The following is a description of a gene set: Mouse Gene Set: FOXD3_TARGET_GENES species: Mus musculus from publication Yevshin I, Sharipov R, Kolmykov S, Kondrakhin Y, Kolpakov F (PMID 30445619) Genes containing one or more binding sites for (Foxd3) in their promoter regions (TSS -1000,+100 bp) as identified by GTRD version 20.06 ChIP-seq harmonization., and this is the list of marker genes: Myo6, Mdm4, Tbc1d15, Cntnap5b, Armc9, Ighv8-2, Serpina3h, Snx5, 1700008O03Rik (RIKEN cDNA 1700008O03 gene), Gm11335, Mobp, Or2t43 (olfactory receptor family 2 subfamily T member 43), H3f3b, H2bc22, Snord3a, Cntnap2, Noct, Oxr1, Gm10222, Chd2, Grcc10, Wrap53, H2ac8, Mroh6, H4c9, Zfp74, Tmsb15l, Aloxe3, 2310016D23Rik, Platr6, Gm23143, Adcyap1, Glra1, Gm11528 (predicted gene 11528), Gm3329, Rbpj, Rpgrip1, H3c6, Gpr19, Slc39a3, Cerkl, Il33, Nnmt, Igf1, Csdc2, Snora24, H3c1, Trim36, H3c13, Med16, Fundc1 (FUN14 domain containing 1), Slco2a1, Snord22, Arsi, Nbr1, Ccdc162, Gm11398, Vangl1, Mir290a, Pax6, Avpi1, Lmo4, Cacnb1, Platr8, Tm6sf1, Bdnf, Irak3, Pbx4, Mras, Gm14443, Aasdh, Snx13, Asxl1, Rpl10a, Mir367 (microRNA 367), Cep112, Krt86, Slc9a2, H2bc18, Arl8b, Clk4, H2bc6, Cept1, Fli1, Gm13580, Dennd2c (DENN domain containing 2C), Ctxn2, Cep120, H1f1, Lhx3, Zfp933, Tmem63b, Capsl, Snord13, Snx1, Mapk8ip2, 1700109H08Rik, Apol6 (apolipoprotein L 6), Rnu7, C230035I16Rik, Car10, H2ax, Slc2a3, Chrna9 (NCBI Gene Id 69992), Bola2, Mrfap1, 2610005L07Rik, Thrap3, Gm16096, Slc25a40, Ube2e1, Cyth3, Gjc1, Gm7546, H1f2, H2bc15, Slc5a11, Tceal8, Ncoa3, Hlf, Stmn1, 5830468F06Rik, Foxp1, Mfsd4b5, Slc4a1ap, Spic, Bbs2 (Bardet-Biedl syndrome 2), B3galt4, Platr11, Hs3st2, Tob1, Tmem220, Sbno1, Gm16249, Klhl5, Tdh, Snord49b, Defb1, Twf1, Rbp7, Fgfr2, Rabgap1l, Atxn7l1, Sbds, 2410006H16Rik, Snord43, Neurod4, Liph, Omg, Pgk1, Htr1a (5-hydroxytryptamine (serotonin) receptor 1A), 4930556M19Rik, 9330185C12Rik, Mup6, Ucn, Gm11862, H4c14, Gm23887, Alyref2 (NCBI Gene Id 56009), Crlf1, Stk38, 1700019D03Rik, Polr2a, Scamp1, Tmem131l, Peli2, Pag1, Gm25323, Upp1, Spp1, Acsl6, Eif4a2, Ntn1, H4c4, Ccdc92b, Lrrtm3, Dner, Mrpl58, Phc1, Gm12974, H3c3, Jarid2, Mir122, 2700078F05Rik, Frmd4b, 2410021H03Rik, Hecw2, Ipo11, Or8u8, C430039J16Rik, Skap2, Kctd4, Usp49, Eapp, H2ac15, Gm25878, Gpd2, Srsf2, Pramel7, Tmsb15b1, Gm27217, Gm26907, H1f3, A230072E10Rik, Ebi3, Cbx2, Ap2a2, Atp6v0a1, 1700109G14Rik, Gm14292, Snhg3, Lrrc2, Fancd2os, Pml, Gm11517, Arl6ip1 (NCBI Gene Id 97394), Ldlrad3, H4c6, 4930503O07Rik, A530020G20Rik, Glra2, Zc3h10, Itga6, Mcf2, Rad23a, Cidea, 1700021P04Rik, Zfp976, Car3, Eef1a1, Rps26, Snora73b, Eif4e1b, Cdhr18, Mroh3, Xiap, Xpa, Rcc1, Lpar1 (lysophosphatidic acid receptor 1), Uba2, Rny3, Cxcl11, Brd2, Madd, Gm15660, H2ac4, Alg13, Msh4, Mir302c, Ang2, Gm22513, Prps1, Klf4, Tlr3, Etv5, Trp53bp1, Tti2 (TELO2 interacting protein 2), Lamc3, Mir302d, Fbxo15, Atp6v0a4, Gm35048, H2bc3, Sfrp4, Tgm4, Snhg8, Pdzk1, Zfp212, Ogt, Plcd4, Gm11850, Rnf125, Pde7b, Gm11747, Fis1 (NCBI Gene Id 66437), Mgme1, Gm7804, Plekha1, H2bc12, Gm17501, Tph2, Dhx32, Trim69, Hnrnpu, Nop58, Egr1, Oas1a, Lpar6 (lysophosphatidic acid receptor 6), Cpsf4l, Traf3ip2, Gm25939, Gm26444, Stx1a, Spink1, Fam124b, H3c10, Rerg, Rnu11, Arf4, Dnah14, C330002G04Rik, 4930442L01Rik, Gm25053, Mterf2, Tmem11, Trbv31 (NCBI Gene Id 269846), Porcn, Gm12017, Arl5b, Tdrp, Tg, H2ac11, Nudt3, H2-T24, Mroh1, Agtrap, H2bc8, Gm22744, Rev1, Slc25a1, Zfand6, Tmcc1 (transmembrane and coiled coil domains 1), Sms, H4c3, Schip1, Scpep1os, Prkci, Armcx1, Mir292, Scn2a, Ackr4, Ctbp2, Scg2, Hmgxb4 (NCBI Gene Id 70823), Gm23246, Garin1a, Emc4, Lss, N4bp2, Gm28857, Gls, Mir291b, Gm16510, Cacng3, Pura, Cadps, Snapc5, Fgfr1, Yars2, Slc38a2, Trip12, Scmh1, Setd5, H4c1, 4930453N24Rik, Cdkl3, Npdc1, Btf3-ps11, Poldip3 (NCBI Gene Id 97955), Mbnl1, Mtcl1, 1600014C10Rik, Cpeb3, Barhl1, Rnu12, Gapdh, Supt7l, Il1rapl1, Golga1, Gramd1a, Pef1, Ubc, Gm20609 (NCBI Gene Id 102637684), Oas1g, H4c12, Skp1 (NCBI Gene Id 76591), H2af-ps2, Rpl3, 4933417E11Rik, Snx10 (NCBI Gene Id 71982), Ssr2, Atf7ip, Fam169a, Rxfp3, Gt(ROSA)26Sor, Mir6236, Dapk3, Capzb, Gm9791, Mir302a, Gm12925, Trem2, Zfp975, Nrf1, H2ac5-ps, Vwc2l, Eif4g2, Mfsd11, Hmga1, Fbll1, Mtf2, Prcc, Lrpap1, Tead1, Dbf4, Prdx1, Klhl26, Fhit, Gm2559, 4930558J22Rik, Gm24016, Chm, Gm3822, 2700049A03Rik, Eddm13, Gm25867, Casd1, Lmbrd1, Polg2, Adgrg5, Gm22680, Gm29340, Mcc, Gm23613, Gm36401, Rgs12, Dpm1, Adgrl2, Hectd2os, Timp4, Nup160, Platr26, Abca4, Mtus1, Afp, Fth1, 2500004C02Rik, Gm2824, Gm22827 (predicted gene, 22827), Gm26703, Ttc39d, Mageb16, Cfap70, H2bc13, Anxa11, Gm6446, Tesc, Ptges3, Trmt13, Mir291a, Gm22973, Gm14393, Cd2, Ctc1, Myo10, Cadps2, Nefm, Gm2427, Mir302b (NCBI Gene Id 723948), Snora73a, Sirt1 (sirtuin 1), Tfpi, Cimip4, Kat6a, Gm8242, Atp8a1, Znfx1, Hspa8, Scrt1, Lcp1, Dusp1, Abi3, Urgcp, Prrc2a, Vps51, Ghsr, Meis3, Platr27, Ttn, Cyb5r4, Gm12185, Gtf3c6, Slc39a14, Igf2bp2, Otx2, Tbx3, Xist, Fmr1nb, Gid8, Arsg, Tpd52, Zfas1, Ehf, Mir1894, Elovl6, Dok2, H4c8, Mrpl4, Rlim, Gbp5, Gm15067, Ptk2b, Fgfbp1, Rps19-ps5, Creb3l2, Slc7a3, Gm9905, Cacng2, Gm24432, Gjb3, Commd3, Mcl1, Abcg2, Gm25336, Prickle1, Gm26802, Gm34767, Mir7b, Gm2673, H3c8, Malat1, Tgtp1, Rfc4, Kcnj8, Gm24453, Ralgapb, Sulf1, H2ac12, Vwa3b, Adgrb3, Pcdhgc4 (protocadherin gamma subfamily C, 4), Ubb, Tex14, Rnf182, Ftl1, Gm43700, Tmem141, Srsf7, Ndrg4, Zfp1004, Gm28888, Dnajb4, Chit1, Rdh10, Pdzd2, Tgm3, H1f4, Gm14133, Cdc23, Snord49a, Gm9429, Rps20, Nfyc, Pomp, H3c7, Gngt2, Gm13629, Pcbp2, Cdh2, Gm22661, Gm4705, Apela, Foxn3, Npm3-ps1, H2ac14-ps, Gm16152, Ddx60, Arhgap12 (Rho GTPase activating protein 12), Rabgef1, Usp10, Pclo, Gm12100, Sec11a, Gm1070 (predicted gene 1070)